Given this list of marker genes SH3GLB1, ATP8B1, FASLG, CASP7, WASL, MYH9 (myosin heavy chain 9), SYTL4, ASAP1, DNM2, ATP10A, RAB3A, S100A10, NOX5, GSN, AHNAK, ANXA2, XRCC4, here is a description of the gene set: Human Gene Set: GOBP_REGULATION_OF_PLASMA_MEMBRANE_ORGANIZATION species: Homo sapiens Any process that modulates the frequency, rate or extent of plasma membrane organization.